The following is a description of a gene set: Perhaps the most important and widely studied blood group is the ABO blood group. It consists of antigens found on the outer surface of red cells and corresponding antibodies in plasma. The majority of the world's population (~80%) are 'secretors' which means that the antigens present in their blood will also be found in other body fluids such as saliva. An individual can be a Secretor (Se) or a non-secretor (se) and this is completely independent of whether the individual is of blood type A, B, AB, or O. From a very early age, the immune system develops antibodies against whichever ABO blood group antigens are not found on the individual's RBCs. Thus, a blood group A individual will have anti-B antibodies and a blood group B individual will have anti-A antibodies. Individuals with the most common blood group, O, will have both anti-A and anti-B in their plasma. Blood group AB is the least common, and these individuals will have neither anti-A nor anti-B in their plasma.<br><br>The primary structure of these antigens is an oligosaccharide precursor sequence on to which one or more sugars are attached at specific locations. The blood group oligosaccharide antigens A, B and H are produced by enzymes expressed by these genes and form the basis of the ABO 'blood type' phenotypes. A and B antigens were originally identified on red blood cells (RBCs) but later identified on other cell types and in bodily secretions. The ABO blood group system is important in blood transfusion, cell/tissue/organ transplantation and forensic evidence at crime scenes.<br><br>The H antigen is formed with the addition of a fucose sugar onto one of two precursor oligosaccharide sequences (Type 1 chains are Gal β1,3 GlcNAc β1,3 Gal R and Type 2 chains are Gal β1,4 GlcNAc β1,3 Gal R; where R is a glycoprotein (Type 1) or glycosphingolipid (Type 2). Type 2 chains are only found on RBCs, epithelial cells and endothelial cells. The <i>H</i> gene expressed in hematopoietic cells produces α-1,2-fucosyltransferase 1 (FUT1) which adds a fucose to Type 2 chains to form the H antigen in non-secretors. Type 1 chains are found in secretors. The <i>Se</i> gene expressed in secretory glands produces α-1,2-fucosyltransferase 2 (FUT2) which adds a fucose to Type 1 chains to form the H antigen in secretors.<br><br>The H antigen is abundant in individuals with blood group O and is the essential precursor for the production of A and B antigens. A and B antigens are formed by the action of glycosyltransferases encoded by functional alleles at the ABO genetic locus. The co dominant A allele encodes A transferase, which transfers an N acetylgalactosamine (GalNAc) sugar to the H antigen forming the A antigen. Similarly, the co dominant B allele encodes B transferase, which transfers a galactose (Gal) sugar to the H antigen forming the B antigen. Individuals who have both A and B alleles form the AB antigen. Individuals who are homozygous for the recessive O allele express the H antigen but do not form A or B antigens as they lack both the glycosyltransferase enzymes for their formation. Mutant alleles of the corresponding FUT1 or FUT2 genes result in either a H– phenotype (Bombay phenotype, Oh) or a weak H phenotype (para Bombay) where the affected individual cannot form H, A or B antigens. The biosyntheses of the A, B and H antigens are described in this section (Ewald & Sumner 2016, Scharberg et al. 2016).<br> Reactome Pathway: ABO blood group biosynthesis part of: Blood group systems biosynthesis species: Homo sapiens, and this is the list of marker genes: FUT1, ABO, FUT2